Given this list of marker genes CDKN2D, UBA52, AGO3, MIR24-1, SP1, CDKN2C, TP53, ETS2, MIR24-2, CDKN2B, TNRC6A (NCBI Gene Id 92763), TFDP2, MDM4, UBC, E2F3, AGO1 (NCBI Gene Id 26523), E2F2, CDK6, MDM2, CDK4, MAPK3, RPS27A, TFDP1, TNRC6B, ETS1, RB1 (NCBI Gene Id 92728), CDKN2A, E2F1, MAPK1, MOV10, AGO4, UBB, TNRC6C, ERF, ID1, here is a description of the gene set: species: Homo sapiens Oncogene-induced senescence (OIS) is triggered by high level of RAS/RAF/MAPK signaling that can be caused, for example, by oncogenic mutations in RAS or RAF proteins, or by oncogenic mutations in growth factor receptors, such as EGFR, that act upstream of RAS/RAF/MAPK cascade. Oncogene-induced senescence can also be triggered by high transcriptional activity of E2F1, E2F2 or E2F3 which can be caused, for example, by the loss-of-function of RB1 tumor suppressor.<br><br>Oncogenic signals trigger transcription of CDKN2A locus tumor suppressor genes: p16INK4A and p14ARF. p16INK4A and p14ARF share exons 2 and 3, but are expressed from different promoters and use different reading frames. Therefore, while their mRNAs are homologous and are both translationally inhibited by miR-24 microRNA, they share no similarity at the amino acid sequence level and perform distinct functions in the cell. p16INK4A acts as the inhibitor of cyclin-dependent kinases CDK4 and CDK6 which phosphorylate and inhibit RB1 protein thereby promoting G1 to S transition and cell cycle progression. Increased p16INK4A level leads to hypophosphorylation of RB1, allowing RB1 to inhibit transcription of E2F1, E2F2 and E2F3-target genes that are needed for cell cycle progression, which results in cell cycle arrest in G1 phase. p14-ARF binds and destabilizes MDM2 ubiquitin ligase, responsible for ubiquitination and degradation of TP53 (p53) tumor suppressor protein. Therefore, increased p14-ARF level leads to increased level of TP53 and increased expression of TP53 target genes, such as p21, which triggers p53-mediated cell cycle arrest and, depending on other factors, may also lead to p53-mediated apoptosis. CDKN2B locus, which encodes an inhibitor of CDK4 and CDK6, p15INK4B, is located in the vicinity of CDKN2A locus, at the chromosome band 9p21. p15INK4B, together with p16INK4A, contributes to senescence of human T-lymphocytes and mouse fibroblasts. SMAD3, activated by TGF-beta-1 signaling, controls senescence in the mouse multistage carcinogenesis model through regulation of MYC and p15INK4B gene expression. TGF-beta-induced p15INK4B expression is also important for the senescence of hepatocellular carcinoma cell lines.<p>MAP kinases MAPK1 (ERK2) and MAPK3 (ERK1), which are activated by RAS signaling, phosphorylate ETS1 and ETS2 transcription factors in the nucleus. Phosphorylated ETS1 and ETS2 are able to bind RAS response elements (RREs) in the CDKN2A locus and stimulate p16INK4A transcription. At the same time, activated ERKs (MAPK1 i.e. ERK2 and MAPK3 i.e. ERK1) phosphorylate ERF, the repressor of ETS2 transcription, which leads to translocation of ERF to the cytosol and increased transcription of ETS2. ETS2 can be sequestered and inhibited by binding to ID1, resulting in inhibition of p16INK4A transcription.<br><br>Transcription of p14ARF is stimulated by binding of E2F transcription factors (E2F1, E2F2 or E2F3) in complex with SP1 to p14ARF promoter.<br><br>Oncogenic RAS signaling affects mitochondrial metabolism through an unknown mechanism, leading to increased generation of reactive oxygen species (ROS), which triggers oxidative stress induced senescence pathway. In addition, increased rate of cell division that is one of the consequences of oncogenic signaling, leads to telomere shortening which acts as another senescence trigger.<br>While OIS has been studied to considerable detail in cultured cells, establishment of in vivo role of OIS has been difficult due to lack of specific biomarkers and its interconnectedness with other senescence pathways. part of: Cellular Senescence Reactome Pathway: Oncogene Induced Senescence